Given this list of marker genes Cyld, Kdm6a, Kcnh5, Ms4a4b, Tmed5, Tshz1, Zfp984, Cdc37l1, Tbpl2, Pdgfrl, Lnx1, Errfi1, Dab2ip (NCBI Gene Id 98996), Iqck, Heph, Etfbkmt, Fgd4, Fam110c, Trpc3, Slc25a32, Zeb1, Zfp367, Csnk1g3, Zfp268, Bmp2k, Psma2, Vcl, Rerg, Nr1h5, Fstl4, Slc17a8, Csmd3, Sgip1, Ssr3 (NCBI Gene Id 99923), Pla2g4e, Poglut2, Map3k9, Pitpnc1, Grhl1, Mybl1, Ubxn7, Ube2q2, Ythdc1, Ahr, Olig3, Tmcc1, Zfp711, G2e3, Prr16, Stab2, Ppp1r14bl, Cdkl1, Slc25a40, Nfatc3, Npnt, Ccn3, Tsc22d2, Zfp182, Snx6, Ehf, Dhx32 (DEAH-box helicase 32 (putative)), Hnrnpd (heterogeneous nuclear ribonucleoprotein D), here is a description of the gene set: Mouse Gene Set: MIR_1A_1_5P from publication Chen Y, Wang X (PMID 31504780) Genes predicted to be targets of miRBase v22 microRNA mmu_miR_1a_1_5p in miRDB v6.0 with MirTarget v4 prediction scores > 80 (high confidence targets). studied in species Mus musculus